Given this list of marker genes Foxc2, Tgfa, Egfr, Pitx2, Mapk3, Map3k1, Smad4, Jun, Inhbb, Fgfr2, Dkk2, Sfrp1, Notch1, Smad1, Smad5, Shh, Fgf10, Foxc1 (NCBI Gene Id 17300), Mapk9, Bmp4 (bone morphogenetic protein 4), here is a description of the gene set: species: Mus musculus BMP signaling pathway in eyelid development Mouse Gene Set: WP_BMP_SIGNALING_PATHWAY_IN_EYELID_DEVELOPMENT